Given this list of marker genes Hip1, Pstpip1, Bfsp2, Mlph, Stil, Capza1, Crip2, Csnk1g2, Bfsp1, Exoc3l, Rab10, Mark2, Ank1, Arhgef9, Stox1, Inpp5d (NCBI Gene Id 98312), Ctnnb1, Emd, Pls1, Kdf1, Cldn5, Llgl2, Pkd2, Map2k2, Shroom1, Septin7, Numa1, Sapcd2, Myo1a, Ctnnd1, Tpm3, Ptk2b, Cobl, Glrx3, Dbn1, Tsc1, Vmn2r1, Septin9, Fgg, Actn3, Cdh1, Cib2, Shroom4, Tbcb, Prkcb, Lamc2, Fryl, Trip10, Cytip (NCBI Gene Id 98984), Nrbp1, Exoc2, Rimbp2, Exoc8, Cnksr1 (connector enhancer of kinase suppressor of Ras 1), Coro1a, Itpr2, Capzb, Tnfaip2, Sptbn5, Snx9, Fer, Akap13, Cep85, Gsn, Astn2, Erc1, Epb41l2, Epb42, Ppp1r9a, Stim1, Fgfr2, Myo5b, Gucy1b1, Pxn, Med28, Stxbp1, Myrip, Myo1d, Lasp1, Piezo1, Rasal3, Septin3, Pnma5, Ooep, Actb, Traf6, Eno2, Mkln1 (muskelin 1, intracellular mediator containing kelch motifs), Arc, Ocm, Myh9, Exoc3l4, Fmn2, Grb2, Nf2, Cd2ap, Axin1, Fnbp1l, Marcks, Fnbp1, Rims1, BC034090, Arhgef7, Grm7, Myh10, Iqgap3, Fabp2, Gmfg, Arf6, Myo1c, Wdpcp, Actn1, Exoc3l2, Hmcn2 (hemicentin 2), Fgb, Hcls1, Ctbp2, Gnai1, Asph, Prkcz, Sptbn4, Dbnl, Mpp7, Dmtn, Cald1, Actr2, Hamp, Slc4a1, Tpm4, Fga, Drd4, Coro1c, Fabp1, Slc2a1, Pclo, Myl12b, Clip2, Hmcn1, Erc2, Grk4, Grip1, Ppfibp1, Snap25, Epb41, Iqgap2, Misp, Actn2, Dstn, Ptk2, Myadm, Clip1, Cav1, Dlg4, Melk, Pard6a, Septin10, Phldb2, Tchp, Fchsd1, Sh3bp1, Psen1, Vcl, Flot2, Pde4dip, Apc, Cttnbp2, Ctsz, Myl12a, Gmfb, Clip4, Tmem201, Cotl1, Nr3c2, Anxa2, Fgf1, Wasl, Actn4, Ect2, Rac1, Spta1, Hnrnpk (NCBI Gene Id 15387, heterogeneous nuclear ribonucleoprotein K), Bin2, Ccn2, Nedd4, Sptan1, Rims3, Ncl, Pard6b, Pdlim2, Exoc6b, Khdc3, Wdr1, Capza3, Capza1b, Myl9, Ppp1r9b, Ctbp1, Maea, Nedd9 (neural precursor cell expressed, developmentally down-regulated gene 9), Insc, Myo1f, Rims2, Washc1, Tle6, Ric8b, Ilk, Septin12, Myo1e, Osr1, Agtrap, Osbpl8, Septin14, Slc38a8, Mpp1, Iqgap1, Dctn1, Myo7a, Gad1, Prkd1, Add3, Exoc6, Eps8 (NCBI Gene Id 13860), Mtss2, Rdx, Cfl1, Scnn1a, Cdh2 (NCBI Gene Id 12558), Septin11, Clic5, Myzap, Krt19, Cdc42se1, Clasp2, Pla2g4c, Exoc4, Pafah1b1, Stk39, Trpv4, Fam110a, Actr1a, Septin8, Ric8a, Flnb, Flna, Eef1a1, Myo9b, Fry, Hamp2, Flot1, Dlc1, Ppfia3, Gys2, Septin5, Sele, Exoc3, Stimate, Gypc (NCBI Gene Id 71683), Tmc2, Iqsec2 (IQ motif and Sec7 domain 2), Nlrp5, Kncn, Sptb, Fam110c, Eno1, Exoc5, Calb2, Or2c1, Ezr, Hfe, Arhgap33, Daxx, Exoc1, Pard6g, Piezo2, Rtkn, Phldb1, Bsn, Kcnc3, Spire2, Frmpd1, Trak1, Spire1, Col10a1, Anln, Llgl1, Septin6 (NCBI Gene Id 80615), Gab1, Hip1r, Septin4, Shroom3 (shroom family member 3), Sptbn1, Capza2, Snca, Shroom2, Myo10, Rhoa, Dvl2 (dishevelled segment polarity protein 2), Exoc7, Ndfip1, Pvalb, Dctn4, Cd302, Unc13a, Macf1, Ermn, Fermt2, Myh2, Lancl2, Gipc1 (NCBI Gene Id 67903), Nos2, Dync1h1, Osbpl2, Zhx3, Pjvk, Tmod1, Epn3, Itch, Nsmf, Plekhh2, Ctnna2, Dennd2b, Pdzd4, Calb1, Clip3, Dst, Tcl1, Ryr1, Nlrp4f, Mapre1, Map2k1, Gck, Sprr4, Eno1b, Pfn1, Pard3, Gpsm1, Pard3b, Cap1, Mical3, Arfip2, Cttn, Spink5, Arv1, Gpsm2, C2cd2l, C2cd5, Arhgap32, Pfn4, Rapgef3, Septin1, Akt2, Hax1, Rai14, Itgb4, Traf2, Septin2, Trpc4 (transient receptor potential cation channel, subfamily C, member 4), Sptbn2, Fscn1, Kif21a, Clasp1, here is a description of the gene set: The region of a cell that lies just beneath the plasma membrane and often, but not always, contains a network of actin filaments and associated proteins. studied in species Mus musculus Mouse Gene Set: GOCC_CELL_CORTEX